The following is a description of a gene set: A phospholipid scrambling process that results in the appearance of phosphatidylserine on the outer leaflet of the plasma membrane of an apoptotic cell, which acts as an 'eat-me' signal for engulfing cells. Phosphatidylserine is exposed on the apoptotic cell surface by a phospholipid scramblase activity. species: Mus musculus Mouse Gene Set: GOBP_PHOSPHATIDYLSERINE_EXPOSURE_ON_APOPTOTIC_CELL_SURFACE, and this is the list of marker genes: Trpc5, Ano6, Xrcc4, Plscr2, Xkr4, Xkr6, Plscr1, Xkr8, Xkr9 (X-linked Kx blood group related 9), Xkr7, Fasl